The following is a description of a gene set: studied in species Homo sapiens Top genes down-regulated in hormone refractory metastatic prostate cancer compared to localized prostate cancer. from publication Tomlins SA, Mehra R, Rhodes DR, Cao X, Wang L, Dhanasekaran SM, Kalyana-Sundaram S, Wei JT, Rubin MA, Pienta KJ, Shah RB, Chinnaiyan AM (PMID 17173048) Human Gene Set: TOMLINS_METASTASIS_DN Despite efforts to profile prostate cancer, the genetic alterations and biological processes that correlate with the observed histological progression are unclear. Using laser-capture microdissection to isolate 101 cell populations, we have profiled prostate cancer progression from benign epithelium to metastatic disease. By analyzing expression signatures in the context of over 14,000 'molecular concepts', or sets of biologically connected genes, we generated an integrative model of progression. Molecular concepts that demarcate critical transitions in progression include protein biosynthesis, E26 transformation-specific (ETS) family transcriptional targets, androgen signaling and cell proliferation. Of note, relative to low-grade prostate cancer (Gleason pattern 3), high-grade cancer (Gleason pattern 4) shows an attenuated androgen signaling signature, similar to metastatic prostate cancer, which may reflect dedifferentiation and explain the clinical association of grade with prognosis. Taken together, these data show that analyzing gene expression signatures in the context of a compendium of molecular concepts is useful in understanding cancer biology., and this is the list of marker genes: MIA3, NECTIN2, UBE2J1, GRIP1, TM9SF2, TMEM131 (NCBI Gene Id 55369), TMEM87B, ABCC4, MATN3, CTSZ, LPAR6, MESD, IER2 (immediate early response 2), KDELR3, PCM1, TMEM98, TNFSF10, CTBP2, TMEM50B, FOLR3